The following is a description of a gene set: Hepatic fibrosis that reaches from a portal area to another portal area. Hepatic bridging fibrosis Human Gene Set: HP_HEPATIC_BRIDGING_FIBROSIS studied in species Homo sapiens, and this is the list of marker genes: RINT1, FADD, TULP3, USP53, LIPA, CYP7B1, SCYL1 (NCBI Gene Id 57410), KIF12, DCDC2, ATP6AP1